Given this list of marker genes CCL27, CCR9, CCL16, CXCL10, CCL28, CCL19, CCL25, CXCR1, ACKR3, CCL5, CCL13, XCL1, CCR3, CXCR6 (C-X-C motif chemokine receptor 6), CCR5, CCR8, CCL3, CCRL2 (C-C motif chemokine receptor like 2), PPBP, ACKR4, CCL20, CCL22, CCL21, CCL11, XCR1, CXCL3, PF4, CXCL5, CCL4, CXCR3, CXCR4, CCR7, CCL3L1, CX3CR1, CXCL12, CXCL2, CCL2, CCL7, CXCL11, CX3CL1, CCR4, CXCL8, CXCL16, CXCR2, CXCL1, ACKR2, CXCL9, CCL1, CCR1, CCR6, CXCR5, CCR10, CXCL6, CCL17, XCL2, CCR2, CXCL13, here is a description of the gene set: species: Homo sapiens Chemokine receptors are cytokine receptors found on the surface of certain cells, which interact with a type of cytokine called a chemokine. Following interaction, these receptors trigger a flux of intracellular calcium which leads to chemotaxis. Chemokine receptors are divided into different families, CXC chemokine receptors, CC chemokine receptors, CX3C chemokine receptors and XC chemokine receptors that correspond to the 4 distinct subfamilies of chemokines they bind. Reactome Pathway: Chemokine receptors bind chemokines part of: Peptide ligand-binding receptors